The following is a description of a gene set: Neighborhood of ELAC2 Human Gene Set: GNF2_ELAC2 Neighborhood of ELAC2 elaC homolog 2 (E. coli) in the GNF2 expression compendium species: Homo sapiens, and this is the list of marker genes: KPNB1, SART3, U2SURP, DDX18, ZCCHC8, BANF1 (NCBI Gene Id 8815), ELAC2, DHX15, HNRNPM, SF3B2 (NCBI Gene Id 170474), SLC7A5P1, PSMC6, PDS5A, SRP54, PSMA1, PRPF31, HNRNPF, PSME2, NAA15, DDX47, RPA1, HDAC1, HNRNPK, PABPN1, TARDBP, SMC1A, RBMX, CPSF6, FUS, HNRNPR, PRPF40A, EXOSC8, SMARCA5, SNRNP200, DDX21, IFT25 (NCBI Gene Id 51668), EED (NCBI Gene Id 8726), ZC3H15, SRSF10, LAS1L, NMT1, HNRNPA3P1, NOP14, SFPQ, SRSF1, NUP62